The following is a description of a gene set: from publication Cui A, Huang T, Li S, Ma A, Pérez JL, Sander C, Keskin DB, Wu CJ, Fraenkel E, Hacohen N (PMID 38057668) Genes negatively differentially expressed in cell type: B cell upon treatment with cytokine: Noggin in mouse lymph nodes in vivo. Mouse Gene Set: CUI_B_CELL_NOGGIN_RESPONSE_DN Cytokines mediate cell-cell communication in the immune system and represent important therapeutic targets. A myriad of studies have highlighted their central role in immune function, yet we lack a global view of the cellular responses of each immune cell type to each cytokine. To address this gap, the authors created the Immune Dictionary, a compendium of single-cell transcriptomic profiles of more than 17 immune cell types in response to each of 86 cytokines (>1,400 cytokine-cell type combinations) in mouse lymph nodes in vivo. A cytokine-centric view of the dictionary revealed that most cytokines induce highly cell-type-specific responses. For example, the inflammatory cytokine interleukin-1β induces distinct gene programmes in almost every cell type. A cell-type-centric view of the dictionary identified more than 66 cytokine-driven cellular polarization states across immune cell types, including previously uncharacterized states such as an interleukin-18-induced polyfunctional natural killer cell state. studied in species Mus musculus, and this is the list of marker genes: Uba52 (ubiquitin A-52 residue ribosomal protein fusion product 1), Fos, Fosb (NCBI Gene Id 14282), Klf2, Junb